The following is a description of a gene set: Human Gene Set: QI_PBMC_ZOSTAVAX_AGE_50_75YO_CORRELATED_WITH_CONTRACTION_OF_VZV_SPECIFIC_T_CELLS_PEAK_TO_28DYAT_1DY_NEGATIVE Genes negatively correlated with contraction of VZV specific T cells (peak to 28d) in peripheral blood mononuclear cell in seniors (50-75) after exposure to Zostavax, time point 1D studied in species Homo sapiens from publication Qi Q, Cavanagh MM, Le Saux S, Wagar LE, Mackey S, Hu J, Maecker H, Swan GE, Davis MM, Dekker CL, Tian L, Weyand CM, Goronzy JJ (PMID 27764254) Vaccination with attenuated live varicella zoster virus (VZV) can prevent zoster reactivation, but protection is incomplete especially in an older population. To decipher the molecular mechanisms underlying variable vaccine responses, T- and B-cell responses to VZV vaccination were examined in individuals of different ages including identical twin pairs. Contrary to the induction of VZV-specific antibodies, antigen-specific T cell responses were significantly influenced by inherited factors. Diminished generation of long-lived memory T cells in older individuals was mainly caused by increased T cell loss after the peak response while the expansion of antigen-specific T cells was not affected by age. Gene expression in activated CD4 T cells at the time of the peak response identified gene modules related to cell cycle regulation and DNA repair that correlated with the contraction phase of the T cell response and consequently the generation of long-lived memory cells. These data identify cell cycle regulatory mechanisms as targets to reduce T cell attrition in a vaccine response and to improve the generation of antigen-specific T cell memory, in particular in an older population., and this is the list of marker genes: TRIR, VPREB3, UQCR10, RPS26, TOMM22, TPT1, TXNDC17, MICOS13, NT5C3A, PYCARD, TRIM38, MBP, ZNF483, UNC50, PRMT2, RRAGA, C7orf50, RPL23, RPL18A, PCYOX1, MAFF, RPL13P5, ZBP1, COMMD3, KLHL28, GDPD1, C1QBP, NME1-NME2, ERH, TMA7, TRAPPC4, FAM72B, CUTA, FAM238B, COMMD6, NFATC2IP, RTEL1, UPP1, RO60, SNHG5, TDRD1, NDUFA12, CDK13, C12orf57, NDUFS5, MRPL51, ZSWIM8, DUSP23, U2AF1, RPS27L, NCK1, CD8A, SRSF7, RAB27A, KLRF1, RNASE2, PPP1R16B, PTPRCAP, ATP2B1-AS1, SIVA1, FAU, TOMM6 (translocase of outer mitochondrial membrane 6), EIF3M, PDPK1, TAF12, APOBEC3G, TRAPPC1 (NCBI Gene Id 58485), USF2, WASH3P, TUFM, SF3B5, RPS27, CCDC93, SAMD4B, RPS27A, MRPL20, RPS17, SH2D2A, NDUFA13, BLZF1, TMEM160, CLTB, RPL17, KLRB1, AGAP6, ZNF69, ARHGAP9, MBD4, MRPL14, DYRK2, SMIM26, S100P, RPL14, RPL4, DTYMK, HMGN1, SF1, RPL35, GALNT3, NFAT5, RETREG2, DYNLRB1, ISY1, RPL27, MRPS33, CXCR3, SS18L2, ZNF598, RHOC, SEPTIN6, SLC31A1, MRPL54, DUSP19, C4orf3, TNFSF15, PPIAL4A, HTATIP2, FCAR, ARID4B, PRDX1, MT1E, NSUN5, ATP5PD, ARHGEF1, CDK2AP2, MIF, TMEM218, PVALB, RPS3A, CAMKK2, EEF1B2, RPS6KA4, TCP1, RPL36, GRK5, GZMA, GTF2E2, TOMM7, DRAP1, MBTD1 (mbt domain containing 1), RPS5, ZNF91, SNRPD2, TMEM256, DPP9, RBM12B, RPL26, ATP5PF, DUSP1, EEF1D, VPS25, NAA20, ZBTB40, FUT6, MTHFS, CD79B, ITM2A, METTL26, LRPPRC, TMEM9B, M6PR, SPINT1, RPS29, UGP2, MSL3, BOLA2, EEIG1, SF3A3, APEH, LILRA5, PNPT1, ELMOD3, DDX17, PSMB1, GNG11 (NCBI Gene Id 2791), STMN3, GNL3L, PLEKHA1, ANXA2R, POLE4, RPL11, MARCHF6, SLC39A1, UBE2Z (NCBI Gene Id 65264), NDUFB5, STAG3L2, COX7B, PTPRC, CARD14, IFI27L2, TYMP, KCNH6, MRPL41, CASP1, TMEM238, DAB2, OCIAD2